Given this list of marker genes PABPN1, THYN1, ZNF789, SPDL1, UNG, DDIAS, RUNX1, GTF3C4, TUBB6, FRAT2, MSH2, ZFP69, RIOX1, POP5, TEX264, EDC3, PEX1, DNAJC11, SUV39H2, RPP40, POP1, ASB6, MAGOH-DT, PIK3R1, MRM2, OSGEPL1, SLC19A2, POLE3 (DNA polymerase epsilon 3, accessory subunit), IRF3, TRMT13, ZNF180, LRR1, NLRP2, GEMIN6, ZNF559, EIPR1, FKBP14, RIPOR1, PNP (purine nucleoside phosphorylase), TP53RK, DDX28, MTMR12, ASTE1, PNPLA6 (patatin like phospholipase domain containing 6), GXYLT1, NAXD, TMTC4, MRPL12, CERK, UMPS, CDC23, FAM78A, FBXO21, NFIA (nuclear factor I A), TRAPPC12, PDE6D, USP46, FLAD1, NUDT6, PPP1R14B, SLC2A9, GABPA, ZCCHC24, NAPEPLD, IFNGR1, NUDT4, GBA2, NAT9, CAMKK1, PIP4K2B, FLVCR1-DT, DSTYK, PRADC1, ATPAF2, GSPT2, RNF166, CIAO3, ZNF641, KBTBD7, POLR3B, G2E3, THNSL1, YLPM1, CEP97, ARL3, TIMM21, DUSP7, AKTIP, PIK3R4, NAP1L5, FAM168B, IRAG2, FBXO33, IRF5, CDC40, MAP7, COQ9, ZNF35, FLVCR2, BAHD1, GMCL1, KLHL42, FASTKD5, DNAL1, HRAS, ELP1, MED29, ASL, COPS6, DIS3L, MED11, TTLL1, GPATCH1, GTF3C5, MRPS2, PLXNA1, DNAJC28, TATDN2, NME6, WDR53, RNF7, NOL11, EXOSC7, DAAM1, BLMH, ADORA2B, INIP, UTP11, POLR2D (RNA polymerase II subunit D), PDIK1L, ARHGAP12, DCAF4, DOK2, IMP4, OIP5-AS1, RLIG1, RANGRF, WNT5B, NCBP2AS2, DHRS4-AS1, ENDOG, DCAF13, CLP1, TNFAIP8L2, SGK1 (NCBI Gene Id 6446), FOS (Fos proto-oncogene, AP-1 transcription factor subunit), MTFMT, C1orf131, MRPL4, UTP25, HS3ST1, TARBP2, CLPP, EXOSC5, RPAP2, URB2, NDUFA5, SETD6, TRMT1, EXO5, NUP37, FAM98A, FAM98B, UBAC1, HRH1, AP3M1, KAT14, ZNF813, ZCCHC17, NFATC3, THAP11, POLR3H, VASH1, ELP6, DNAAF2, TSPYL5, PRMT7, TOMM40L, MRPS11, MTFR2, MRTFA, MCEE (methylmalonyl-CoA epimerase), ZNF30, MED31, GATC, BRIX1, ZNF227, MRPS33 (mitochondrial ribosomal protein S33), USP38, TRMT10C, TNRC18, CCDC12, ATP2A3, HENMT1 (NCBI Gene Id 113802), PLEKHJ1 (NCBI Gene Id 55111), SEC22C, NAIF1, HSD17B10, ZNF319, here is a description of the gene set: Human Gene Set: GSE18791_CTRL_VS_NEWCASTLE_VIRUS_DC_10H_UP Genes up-regulated in comparison of control conventional dendritic cells (cDC) at 0 h versus cDCs infected with Newcastle disease virus (NDV) at 10 h. from publication Zaslavsky E, Hershberg U, Seto J, Pham AM, Marquez S, Duke JL, Wetmur JG, Tenoever BR, Sealfon SC, Kleinstein SH (PMID 20164420) The dendritic cell (DC) is a master regulator of immune responses. Pathogenic viruses subvert normal immune function in DCs through the expression of immune antagonists. Understanding how these antagonists interact with the host immune system requires knowledge of the underlying genetic regulatory network that operates during an uninhibited antiviral response. In order to isolate and identify this network, we studied DCs infected with Newcastle Disease Virus (NDV), which is able to stimulate innate immunity and DC maturation through activation of RIG-I signaling, but lacks the ability to evade the human interferon response. To analyze this experimental model, we developed a new approach integrating genome-wide expression kinetics and time-dependent promoter analysis. We found that the genetic program underlying the antiviral cell state transition during the first 18-hours post-infection could be explained by a single regulatory network. Gene expression changes were driven by a step-wise multi-factor cascading control mechanism, where the specific transcription factors controlling expression changed over time. Within this network, most individual genes are regulated by multiple factors, indicating robustness against virus-encoded immune evasion genes. In addition to effectively recapitulating current biological knowledge, we predicted, and validated experimentally, antiviral roles for several novel transcription factors. More generally, our results show how a genetic program can be temporally controlled through a single regulatory network to achieve the large-scale genetic reprogramming characteristic of cell state transitions. studied in species Homo sapiens